The following is a description of a gene set: Human Gene Set: MIR4268 studied in species Homo sapiens Genes predicted to be targets of miRBase v22 microRNA hsa-miR-4268 in miRDB v6.0 with MirTarget v4 prediction scores > 80 (high confidence targets). from publication Chen Y, Wang X (PMID 31504780), and this is the list of marker genes: SGSM2, CDH7, LVRN, BECN1, PHF8, STAT3, MITF, STX17, AGAP1, TMED7-TICAM2, PLXNA4, GJB1, NFYC, PHF3, SLC9A8, CSMD3, GRM7, TICAM2, WDR89, NOC3L, UBE4B, WNT5A, TPM3, LINC02874, RAB6B, CHD3, HOXB6, UPF1, MPZL1, SCAF8, SESN3 (NCBI Gene Id 143686), MYCN, IL6ST, PEA15, UBE2K, HS6ST3, PLCD3, DYRK1A (NCBI Gene Id 1859), FHIP2B, MTCL1, OSCP1, PTGR3, BBS5, DUSP6, ZNFX1, PLCL1 (NCBI Gene Id 5334), CBR1, SNX1, GABRP (NCBI Gene Id 2568), SAMD13, SCARA5, HTR5A, PAN3, ZER1, CCN1, SOX7, NDUFC2-KCTD14, CCL28, SLC4A4, FAM177A1